Given this list of marker genes Frs2, Tenm4, Acvr2a, Lhx1, Nat8, Nat8f5, Crb2, Ets2, Nat8f3, Lrp5, Acvr1, Gdf3, Prickle1, Nat8f1, Nat8f2, Ctnnb1, Wnt5a, Zbtb17 (zinc finger and BTB domain containing 17), Srf, Gata4, Foxa2, Otx2, Ldb1, Zic3, Ugdh, Nsd1, Plpp3, Rnf2, Megf8, Nodal, Amot, Lrp6, Dact1, Hhex, Chrd, Smad4, Acvr2b, here is a description of the gene set: Mouse Gene Set: GOBP_GASTRULATION_WITH_MOUTH_FORMING_SECOND A gastrulation process in which the initial invagination becomes the anus and the mouth forms second. studied in species Mus musculus